The following is a description of a gene set: studied in species Homo sapiens CXCL12-CXCR4-PKC-ERK signaling pathaway. Pathway ID: N00546. Pathway type: Reference. Pathway class: nt06263 Hepatocellular carcinoma. Human Gene Set: KEGG_MEDICUS_REFERENCE_CXCL12_CXCR4_PKC_ERK_SIGNALING_PATHAWAY Pathway Definition from KEGG: CXCL12 -> CXCR4 -> GNAQ -> (PLCB,PLCG) -> IP3 -> Ca2+ -> PKC -> RAF -> MEK -> ERK, and this is the list of marker genes: PRKCB, BRAF, MAP2K2, MAPK1, PLCG2, PLCG1, MAP2K1, PRKCG, CXCL12, CXCR4, PRKCA, PLCB4, PLCB3, MAPK3, GNAQ, PLCB1, ARAF, PLCB2, RAF1